Given this list of marker genes FN3KRP, FOSL2, PLAUR, GTF2IRD1, DAPK3, SPATA2L, SENP5, IL1RAP, SYNJ2, TNFAIP3, CAPRIN2, DUSP5, CSPG4, TNFAIP1, RGS4, RCOR1, IFNGR2, CYP51A1, CSNK1D, IMPA1, RGPD5, CERS6, PLEKHG3, MTMR1, BMPR2, GLIPR1, CCL2, ZFP36L1, ZEB1, AKAP12, DOK5, ABHD10, NPC1, MBP, PTPRE, NFATC1, SMAD3, FGF5 (fibroblast growth factor 5), ARHGAP29, PRKCI (protein kinase C iota), SMCO4, UCP2, IER3, IL2RA, SLC20A1, LEF1, HMGA1, BAHD1, IER2, BAZ1A, TRGC1, LITAF, GEM, RAB40B, FERMT2, ZYX, DNMBP, SERPINE1, GFPT2, EVI2B, SFN, TRIB1, TPBG, SYDE1, MYO1E, TRIO, CDC42SE1, FOXC1, NFKBIE, RND3, NAB1 (NGFI-A binding protein 1), B3GNT2, SOWAHC, ENO2, ZNF365, SPHK1, ITPKC, COBL, SLC7A1, ATG101, SRSF5, IL4R, ST3GAL5, RRAS2, EGR1, WT1, KCNK1, CSF1 (NCBI Gene Id 1435), GRB10, SPRY2, MAFF, ENC1, ATP13A3 (ATPase 13A3), IL11, PDGFA, SHB, ATP1B1, MSH6, SPRR1B, PDLIM4, CHST3, KLF10, SLPI, UTP3, BBS4, APP, SDC4, HPGDS, HMGCS1, TBX3 (T-box transcription factor 3), PMM2, CX3CL1, PRKCD, VCL, RARA, PRR5, CA2, NR3C1, MYH10, PHLPP2, LAMB3, TMC6, PDE10A, MAP2K3, SH2B2, TIMP3, IQCG, PHLDA2, ETS1, SNAI2, IGF2, CHD7, TIAM1, BAZ2A, HBEGF, TNS1, CDH2, FLNC, EPHA2, SH3BP5, ARC, CCNE2, SLC35G2, FOXD1, ARID5B, FHL2, MAP3K9, CBFB, SF1, TET3, HMGA2, BAIAP2, PTHLH, SRSF6, SPRED2, TM4SF1, PITPNB, C1orf56, CD83, TRAF3, ATP2B1, RAB15, FGF1, CCN1, ZMIZ1, SOX9, CD44, INHBA, CSDC2, HNRNPL (heterogeneous nuclear ribonucleoprotein L), ACTN1, AREG, GLS, BIN3, CARD10, LPAR1, OTUD4, FOSL1, NFKBIA, ACTG1, ARAP2, NR4A1, CSRNP2, CXCL8, TNFRSF12A, PTX3, KLF9, CDK17, PDLIM5, RAI14, SH2B3, TNS3, KCTD5, ST3GAL1, CALD1, MYC, RELB, ACTB, SRF, PDGFRA, SGK1, EREG, KDM6B, LIF, JUNB, NFKB2, NFKB1 (NCBI Gene Id 4790), PCDH7, WWTR1, THBS1, C3orf52, MAPK1IP1L, BHLHE40, LBH (LBH regulator of WNT signaling pathway), KRT17, F3, DNAJB5, here is a description of the gene set: Human Gene Set: KIM_WT1_TARGETS_UP The Wilms' tumor suppressor gene (WT1) encodes a zinc finger transcription factor that is vital during development of several organs including metanephric kidneys. Despite the critical regulatory role of WT1, the pathways and mechanisms by which WT1 orchestrates development remain elusive. To identify WT1 target genes, we performed a genome-wide expression profiling analysis in cells expressing inducible WT1. We identified a number of direct WT1 target genes, including the epidermal growth factor (EGF)-family ligands epiregulin and HB-EGF, the chemokine CX3CL1, and the transcription factors SLUG and JUNB. The target genes were validated using quantitative reverse transcriptase-polymerase chain reaction, small interfering RNA knockdowns, chromatin immunoprecipitation, and luciferase reporter analyses. Immunohistochemistry of fetal kidneys confirmed that a number of the WT1 target genes had overlapping expression patterns with the highly restricted spatiotemporal expression of WT1. Finally, using an in vitro embryonic kidney culture assay, we found that the addition of recombinant epiregulin, amphiregulin, CX3CL1, and interleukin-11 significantly enhanced ureteric bud branching morphogenesis. Our genome-wide screen implicates WT1 in the transcriptional regulation of the EGF-family of growth factors as well as the CX3CL1 chemokine during nephrogenesis. from publication Kim HS, Kim MS, Hancock AL, Harper JC, Park JY, Poy G, Perantoni AO, Cam M, Malik K, Lee SB (PMID 17430890) studied in species Homo sapiens Genes up-regulated in UB27 cells (osteosarcoma) at any time point after inducing the expression of a mutant form of WT1.